Given this list of marker genes LGR4, YAP1, PITX2, PTK6, ACVR2B, BBS7, FGF10 (fibroblast growth factor 10), EPHB3, NODAL, CPS1, DCHS1 (dachsous cadherin-related 1), HES1 (NCBI Gene Id 3280), ADA, GLI1, ZIC3, PKDCC, NPHP3, SOX10, CCNB1, SALL1, KLF5, DNAAF1, SAV1, SRP54, GLI3, CCDC103, OVOL2, TP73, NKX6-3, CTNNB1, ALDH1A2, DACT1, SFRP5, NIPBL, NPR2, EDNRB, WNT5A, KIT, RB1, C1GALT1, SIX2, NKX3-2, PYY, CDX2, TLR9, GATA6, XBP1, WNT11, SMAD2, PDGFRA (platelet derived growth factor receptor alpha), IHH, NKX2-6, TGFB1, FOXF2, SOX9, CRKL, FOXF1, CDX1, CELA1, TMIGD1, GLI2, IFT172, NCKAP1, MYOCD, CCDC39, VANGL2, FOXL1, HOXD13, HNF1B, HLX, PTF1A, OTC, ASS1, NPY (NCBI Gene Id 4852), SMAD3, RBPMS2 (RNA binding protein, mRNA processing factor 2), CDKN1C, VPS52, MIXL1, CHD8, RCBTB2, GATA4, HIF1A, AHI1, TCF21 (transcription factor 21), HMGCS2 (3-hydroxy-3-methylglutaryl-CoA synthase 2), SPDEF, CXCL8, SLC4A2, COBL, ALX4, HOXA13, RET, TP63, NKX2-3, IGF1, GATA5, INSR, SFRP1, ID2, COL3A1, PDGFC, RARB, SOX11, ASCL1, PKD1, CDX4, CBFA2T2, CLMP, PDGFA, IL6ST, SHOX2, FOXE1, YIPF6, WDR19, TIGAR, EXT1, KCNQ1, CLDN18, CCDC40, SFRP2, BARX1, TNF (NCBI Gene Id 7124), FGFR2, SRC, CCKBR, NKX2-2, EPB41L5, PDX1, WLS, IGF2, NR5A2, SMO, STRA6, PCSK5, SCT, RARRES2, PRDM1, PERCC1, SHH, NOTCH1, TGFB2, HIP1R, EGFR, CYP1A1, WDPCP, SOX17, FGF9, HOXA5, MYB, MIR29B1, MEGF8, AGR2, FZD5, BCL2, here is a description of the gene set: Human Gene Set: GOBP_DIGESTIVE_SYSTEM_DEVELOPMENT studied in species Homo sapiens The process whose specific outcome is the progression of the digestive system over time, from its formation to the mature structure. The digestive system is the entire structure in which digestion takes place. Digestion is all of the physical, chemical, and biochemical processes carried out by multicellular organisms to break down ingested nutrients into components that may be easily absorbed and directed into metabolism.